The following is a description of a gene set: Human Gene Set: GOBP_NEGATIVE_REGULATION_OF_DNA_METABOLIC_PROCESS Any process that stops, prevents, or reduces the frequency, rate or extent of the chemical reactions and pathways involving DNA. species: Homo sapiens, and this is the list of marker genes: DFFB, H1-4, ERCC4, NPPC, HELB, HSF1, WAPL, CSNK2A1, RPS3, TERF1, SUB1, AUNIP, RNF169, ERCC1, SLX4, NUDT16L1, ATM, FANCB, DCP2, TSPYL2 (TSPY like 2), TENT4B, KLHL15, H1-5, SLX1A, TP53, HNRNPA1, SRC, MSH2 (mutS homolog 2), H1-8, XRCC1, CDT1, KAT5, TWIST1, H1-10, PARP3, SMCHD1, GMNN, C1QBP (complement C1q binding protein), MCRS1, STN1, PARPBP, ADIPOQ, TERF2, SLFN11, DACH1, OGG1, SMG6, HCRT, GDF2, DUSP1, TNKS, H1-9P, MRE11, NAT10, SLX1B, MSH6, NMNAT1 (nicotinamide nucleotide adenylyltransferase 1), MAGEF1, TEN1, UBQLN4, TIPIN, DNAJC2, H1-1, PDS5A, KMT5A (NCBI Gene Id 387893), FOXP3, CAMSAP3, EXOSC10, XRCC5, TINF2, CDKN1A, RECQL5, ANKRD1, OTUB1, MLH1, NIBAN2, SENP3, PLK1, HNRNPC, RMI2, ANKLE1, CGAS, RAD50 (RAD50 double strand break repair protein), FBH1, PARP1, TERF2IP, S100A11, H1-2, MAD2L2, HMGA2, TNKS2, NDFIP1, RTEL1, SHLD2, RAD17, ERCC6, POLQ, H1-7, GZMA (granzyme A), SHLD1, H1-3, LIG3, DYNLL1, GNL3L, RADX, RIF1, ACD, MSH3, TTF1, H1-0, POT1, TFIP11, ENPP7, PML, HNRNPU, BCL6, ATR, MIR221, NBN, XRN1, PINX1, ZSCAN4, CDC6, ABL1, CYREN, CTC1, DFFA, PIF1, BLM, GTPBP4, TP53BP1, FBXO5, KCNK2, TIMELESS, H1-6, SHLD3